The following is a description of a gene set: species: Homo sapiens Human Gene Set: FAN_OVARY_CL3_MATURE_CUMULUS_GRANULOSA_CELL_1 from publication Fan X, Bialecka M, Moustakas I, Lam E, Torrens-Juaneda V, Borggreven NV, Trouw L, Louwe LA, Pilgram GSK, Mei H, van der Westerlaken L, Chuva de Sousa Lopes SM (PMID 31320652) Pseudotime analysis using Monocle 3 alpha, that places the progenitor cell population in the middle of a longer trajectory segment, revealed that pGC (CL15) branched to mural GC (CL11) and mature cumulus GC (CL8 and CL3) (Fig. 6a)., and this is the list of marker genes: MT-CO1, PRDX3, PTTG1IP, EML5, TBCA, UQCR10, GRIK1, LAPTM4B, PRR15, GATM, MPST, ELK1, TSHZ2, CNOT7, USO1, MT-ATP6, ENAH, TBC1D4, HNRNPD, ELOB, FST, IGFBP7, YAP1 (NCBI Gene Id 10413), ARPC2, GPX3, PLD3, HIF1A, SLC5A3, BEX1, IRF4, MARCKSL1, PLAAT3, MARCKS (NCBI Gene Id 4082), CBX3, NDUFS5, SIGLEC11, MAOB, TM7SF2, ATRX, KTN1, SELENOP, ZFP36L2, GASK1B, PTRHD1, RHOB, RBP1, TMEM123, LUC7L3, BEX4, HIGD2A, ANXA6, COL4A1, IDH1, GREB1 (NCBI Gene Id 9687), MT-ND3, MT-CYB, PPFIBP1, CLDN11, LSM5, MEX3B, CLIC1, AVPI1, VIT, LMBR1L, LPP, BEX3, SPRR2F, FLNA, IFI27, IFI35, MFAP2, ST3GAL4, S100B, UQCRQ, NDP, SRI, ABCA8, SYNE2, HMGN1, SERPINE2, POLR2I, FAM204A, GABPB1-AS1, RCN2, FHL2, GTF2I, MAGED2, MGST3, NSG1, CCND2, GTF2H5, TNNI3, NUP214, TTC3, NDUFB5, HS3ST1, PHPT1, HUWE1, BAMBI, ATP5MF, FKBP9, DAG1, PPHLN1, RNF7, SEC31A, DMAC1, DONSON, MAP4K4, SOX4, COX6B1, NONO, PEG3, DSP, LSM7, PABPN1, WIPF3, CST3, SMS, BBLN, COX5B, MT-ND4L, TMEM98, KCNQ1OT1, PRKAR2B, PLA2G12A, BTF3L4, TMEM97, XIST, PRDX2, PHF6, STMN1, ATP5ME, TSPAN6, WASF1, DBI, DDAH2, FSCN1, HDAC2, H3-3A, MT-CO2, ZNF428, SFRP4, NEDD8, ACSL4, NDFIP1, PET100, TUBB, MT-CO3, MT-ND4, CD47, GSTA1 (glutathione S-transferase alpha 1), MRPS21, LCMT1, ATP5IF1, NDUFC2, UQCR11, NDUFA3, CAMTA1, VPS35, SOWAHC (sosondowah ankyrin repeat domain family member C), NKTR, VCAN, SRP9, MT-ND5, CFI, OCIAD2, STMP1, SNRPD2, PLEKHJ1, SLC16A1, SPINT2, TRAPPC4, MALAT1, SELENOH (selenoprotein H), CLNS1A, GJA1, COL4A2, HSBP1, HOPX, MZT2B, TMSB10, DPP7 (NCBI Gene Id 29952), CKB, MYH9, SNRPN, ACSM3, PLP1, ID3, MSI2, AKAP9, EPDR1, PRSS23, FAM78A, DDX17, THBS1, GRB14, DAAM1, TCEA3, SEMA6D, LY6E, ATP5MJ, ATP5MC2, HSPG2, CD99, NME4, HSD17B1, GSTA4, CDH2, NDUFA13, COX7C, ITGB1, PPP1R12B, TSPAN7, MYL6, ABLIM1, DST, ATP5PF, PRDX4, NDUFB7, RPS25, GSTP1 (NCBI Gene Id 2950), IGFBP2 (insulin like growth factor binding protein 2), BMPR2, HTRA1, NICOL1, ACTG1, DAPL1, AMH, HS6ST1, EIF4G1, OSBPL1A, APOA1, IVNS1ABP, H1-0, EPHX1, INSR, NDUFS4, TIMM13, KIDINS220, TMEM258, PCBP2, TMSB4X, RPAIN, SCD, MDK, HACD3, MT-ND2, BAX, LGALS3BP, PPDPF, PPP1R14A, DPYSL3, MT-ND1, CMTM6 (CKLF like MARVEL transmembrane domain containing 6)